Given this list of marker genes Ybx3, Gjb3, Gjc1, Sgsm3, Panx1, Gja6, Ccn3, Gjd4, Tjp2, Gjb6, Panx3, Gja1, Gjc3, Dbn1, Gjd3, Gjb2, Gja4 (NCBI Gene Id 14612), Gja3, Des, Gjd2, Gja8, Gjb4, Gjb1, Gjb5, Specc1l, Tjp1, Gjc2, Gje1, Gja5, Skp1, Calb2, Gja10, here is a description of the gene set: A cell-cell junction composed of pannexins or innexins and connexins, two different families of channel-forming proteins. Mouse Gene Set: GOCC_GAP_JUNCTION studied in species Mus musculus